The following is a description of a gene set: Any process that stops, prevents or reduces the frequency, rate or extent of an adenylate cyclase-activating G protein-coupled receptor signaling pathway. Mouse Gene Set: GOBP_NEGATIVE_REGULATION_OF_ADENYLATE_CYCLASE_ACTIVATING_G_PROTEIN_COUPLED_RECEPTOR_SIGNALING_PATHWAY studied in species Mus musculus, and this is the list of marker genes: Arrdc3, Pde2a, Mrap, Aplp1, Gnai2, Mgrn1, Mrap2, Grk2 (NCBI Gene Id 11557), Crtc3, Atp2b4, Pde3a, Pde4d, Oprm1, Ptger3, Sstr4, Oprl1, Grk5